Given this list of marker genes KMT2C, WDR5, SMYD1, SETD1A, SETD3, PRDM9, KMT2A, PRDM7, SMYD3, SETD4 (SET domain containing 4), ASH1L, SETMAR, KMT2B, SETD1B, SMYD2, KMT2D, SETD7, SETBP1, NSD3, here is a description of the gene set: studied in species Homo sapiens Catalysis of the reaction: S-adenosyl-L-methionine + histone H3 L-lysine (position 4) = S-adenosyl-L-homocysteine + histone H3 N6-methyl-L-lysine (position 4). This reaction is the addition of up to three methyl groups to the lysine residue at position 4 of the histone H3 protein. Human Gene Set: GOMF_HISTONE_H3K4_METHYLTRANSFERASE_ACTIVITY